Given this list of marker genes POU5F1, UPP1, DPPA4, LNCPRESS1, NANOG, DNMT3B, TERF1, MICB, HERC5, NLRP7, SEPTIN6, ESRG, here is a description of the gene set: Human Gene Set: KORKOLA_EMBRYONAL_CARCINOMA Male adult germ cell tumors (GCTs) comprise two major histologic groups: seminomas and nonseminomas. Nonseminomatous GCTs (NSGCTs) can be further divided into embryonal carcinoma (EC), teratoma (T), yolk sac tumor (YS), and choriocarcinoma (CC) on the basis of the lineage differentiation that they exhibit. NSGCTs frequently present as mixed tumors consisting of two or more histological subtypes, often limiting correlative studies of clinical and molecular features to histology. We sought to develop a molecular classifier that could predict the predominant histologic subtype within mixed NSGCT tumor samples. The expression profiles of 84 NSGCTs (42 pure and 42 mixed) and normal age-matched testes were obtained using Affymetrix microarrays. Using prediction analysis for microarrays, we identified 146 transcripts that classified the histology of pure NSGCTs samples with 93% accuracy. When applied to mixed NSGCTs, the classifier predicted a histology that was consistent with one of the reported components in 93% of cases. Among the predictive transcripts were CGB (high in CC), LCN2 (high in T), BMP2 (high in YS), and POU5F1 (high in EC). Thus, the expression-based classifier accurately assigned a single predominant histology to mixed NSGCTs, and identified transcripts differentially expressed between histologic components with relevance to NSGCT differentiation. studied in species Homo sapiens from publication Korkola JE, Houldsworth J, Dobrzynski D, Olshen AB, Reuter VE, Bosl GJ, Chaganti RS (PMID 15870693) Genes predicting the embryonic carcinoma (EC) subtype of nonseminomatous male germ cell tumors (NSGCT).